Given this list of marker genes Cbl, Prkca, Grap2 (NCBI Gene Id 17444), Grb2, Kitl, Sh2b3, Pik3r2, Hras, Yes1, Fes, Ptpn6, Stat5b, Grap, Kit, Stat5a, Tec, Lck (NCBI Gene Id 16818), Cma1, Fyn, Vav1, here is a description of the gene set: part of: Signaling by Receptor Tyrosine Kinases electronically inferred by orthology from the curated human pathway Reactome Pathway: Signaling by SCF-KIT This event has been computationally inferred from an event that has been demonstrated in another species.<p>The inference is based on the homology mapping from PANTHER. Briefly, reactions for which all involved PhysicalEntities (in input, output and catalyst) have a mapped orthologue/paralogue (for complexes at least 75% of components must have a mapping) are inferred to the other species. species: Mus musculus